Given this list of marker genes DHRS9, SIK1, MAP4K4, ITGB2-AS1, PKIG, CITED2, SLC23A1, ITPRIP, SMAGP, SP140L, MPP7, KCNA3, FBXO32, ING2, MYH11, PDCD6P1, ENC1, BIN2, RGS2, KAT2B, ZFYVE28, H2BC15, RETREG1, KLHL3, TSC22D1, YPEL5, GPR65, HAUS3, GABBR1, SLC16A5, DNAJB9, IPCEF1, TRPS1, PIK3R5, SOCS3, SCARNA17, TP53INP1, G0S2, PCDH9, SLC2A3, RNF139, ZNF711, FCMR, SULT1B1, FBXL20, PDE4D (NCBI Gene Id 654081), MXI1, BAG3, CCDC69, PGAP3, FAM200B, ZNF528-AS1, LILRA2, FOSL2, ZNF8, KLF7, H2AJ, SKIL, ZNF34, LINC-PINT, FAM228B, ENPP2, ZFAND2A, TPM2, ITGA4 (integrin subunit alpha 4), PF4, ATP2B1-AS1, ZNF394, YPEL2, KIFC2, TNFAIP3, SAT1, MDS2 (myelodysplastic syndrome 2 translocation associated), MEF2D, GADD45B (growth arrest and DNA damage inducible beta), USF3, ABCA2, APOBEC3A, DUSP1, STXBP5, CCDC141, TNRC6B, ADPRM, AHNAK, SLC9A9, CAPN2, RREB1, RP9P, COQ10B, LPAR2, TSC22D3, SPTBN1, BRWD1, AGTPBP1, SUSD3, TNFSF8, TOB1, ELF2, ARRDC3, OSER1, LINC00938, HEBP2, CDKN2A, SC5D, IRS2, DIAPH2, EFHC2, ANKRD36C, H3C1, ATXN1L, YOD1, MYLIP, NPTX1, FAM8A1, ASH1L-AS1, C16orf54, REM2, NR4A2, ASPRV1, TCF7L2, VPS9D1 (NCBI Gene Id 9605), STAG3L4, OTUD1, LPP, SAMHD1, MAFF, SIN3A, PGC, RFX3, KLF4, MYO1G, YPEL3, DDIT4, DAO, MIR646HG, NDRG1, KCNRG, GPATCH2, UBASH3B, RAP1GAP2, SYTL2, ARHGAP21 (NCBI Gene Id 57584), FBXO33, HYKK, JMY, VNN2, PELI2, BTG2, LINC00173, OTULINL, JUNB, TMEM156, HSD17B11 (hydroxysteroid 17-beta dehydrogenase 11), PARP8 (NCBI Gene Id 79668), SYNM, TSPYL4, PNPLA8, CSGALNACT1, PDP1, PCNT, AK5, FRG1JP, SRSF1, C9orf72, TTC32, ZNF256, TSPAN32 (tetraspanin 32), ERP27, SGTB, SGK1, EPHA4, CCDC18-AS1, HLA-DRB6, PTPRJ, KRT73, NSMCE3, SNX29, GADD45A, UCP2, ANKDD1A, ITCH, TRIM73, AMOT, KLHL15, FOS, H1-2, RELL1 (NCBI Gene Id 768211), DENND3, BNIP3L, CSN2, ZNF101 (NCBI Gene Id 94039), LCOR, KAT6A, IRF2BP2, here is a description of the gene set: Genes up-regulated in comparison of untreated CD4 T cells at 0 h versus the cells treated with IL4 and anti-IL12 at 12 h. Human Gene Set: GSE17974_CTRL_VS_ACT_IL4_AND_ANTI_IL12_12H_CD4_TCELL_UP from publication Elo LL, Järvenpää H, Tuomela S, Raghav S, Ahlfors H, Laurila K, Gupta B, Lund RJ, Tahvanainen J, Hawkins RD, Oresic M, Lähdesmäki H, Rasool O, Rao KV, Aittokallio T, Lahesmaa R (PMID 20620947) The aim of this dataset was to study in detail the transcription kinetics initiated by cytokine IL-4 in early differentiation of Th2 cells. studied in species Homo sapiens